The following is a description of a gene set: studied in species Homo sapiens Any process that results in a change in state or activity of a cell or an organism (in terms of movement, secretion, enzyme production, gene expression, etc.) as a result of an interferon-gamma stimulus. Interferon-gamma is also known as type II interferon. Human Gene Set: GOBP_RESPONSE_TO_TYPE_II_INTERFERON, and this is the list of marker genes: IL12RB1 (interleukin 12 receptor subunit beta 1), STXBP4, ZYX, IFNGR2, NR1H3, NOS2, ACTG1, CCL3, SLC22A5, STXBP3, SLC30A8, SEC61A1, LGALS9, GBP6, JAK1, GBP5, STAT1, CCL2 (NCBI Gene Id 6347), CDC42EP4, CALCOCO2, VAMP3, ACTR3, CAMK2A, FLNB, PDE12, DAPK1, AQP4, GSN (NCBI Gene Id 2934), PTPN2, GBP7, TLR3, FCAR, GPR146, CD58, TYK2, IFITM2, SNCA, ADAMTS13, VAMP4, MYO1C, PARP14, DAPK3, HCK, HPX (hemopexin), SLC26A6, CDC37, IL23R, IFITM1, GBP3, DNAJA3, HLA-DPA1, RAF1, CD200, EDN1, NR1H2, STXBP2, RAB43, ZNF697, CDC42, FASLG, KIF5B, TNF, ACOD1, RAB20, RPL13A, IL12B, GAPDH, SIRPA, VPS26B, CITED1, RPS6KB1, OTOP1, CRIPTO, JAK2, MRC1, UBD, MED1, TRIM21, CD40, CIITA, LCN10 (lipocalin 10), IFNG, SYNCRIP, ACTR2, CD74, GBP1, EPRS1, SHFL, PIM1, STX8, STXBP1, CASP1, BST2, CD47, TP53, ASS1, CXCL16, CLDN1, NLRC5, IFNGR1, PARP9, TLR4, IRF1, GCH1, IRGM, IRF8, RAB7B, CCL5, CYP27B1, SLC11A1, STX4, MEFV, GBP4, SP100, PPARG, TXK, TLR2, CDC42EP2, IFITM3, WAS, KYNU, CALM1, GBP2, WNT5A, AIF1, NUB1, ARG1, VIM